Given this list of marker genes Bmpr1a, Dkk1, Sfrp2 (NCBI Gene Id 99743), Fgfr1, Mesp1, Wnt3a, here is a description of the gene set: studied in species Mus musculus Mouse Gene Set: GOBP_REGULATION_OF_MESODERMAL_CELL_FATE_SPECIFICATION Any process that modulates the frequency, rate or extent of mesoderm cell fate specification.